Given this list of marker genes CYP4F22, GCLM, CYP24A1, GGT1, ACY1, CYP27A1, FMO3, CYP7B1, CYP21A2, UGT1A1, SLC35D1, TPMT, OPLAH, CYP2R1, GSS, CYP11B1, CYP11A1, TBXAS1, CYP2U1, CYP27B1, CYP19A1, CYP26C1, MAOA, GCLC, MAT1A, CYP11B2, UGT1A4, FDXR, CYP17A1, CYP26B1, FDX1, CYP1B1 (NCBI Gene Id 1545), AHCY, FDX2, here is a description of the gene set: The ability to process xenobiotica and many endogenous compounds is called biotransformation and is catalysed by enzymes mainly in the liver of higher organisms but also a number of other organs such as kidneys, gut and lungs. Metabolism occurs in two stages; phase 1 functionalisation and phase 2 conjugation. Defects in enzymes in these two phases can lead to disease. Reactome Pathway: Metabolic disorders of biological oxidation enzymes part of: Diseases of metabolism species: Homo sapiens